The following is a description of a gene set: Reactome Pathway: Defective SLCO1B1 causes hyperbilirubinemia, Rotor type (HBLRR) The solute carrier organic anion transporter family member 1B1 (SLCO1B1) is expressed on the basolateral surfaces of hepatocytes and mediates the uptake of bilirubin (BIL), a breakdown product of heme degradation, to the liver where it is conjugated and excreted from the body. Defects in SLCO1B1 can cause hyperbilirubinemia, Rotor type (HBLRR; MIM:237450), an autosomal recessive form of primary conjugated hyperbilirubinemia. Mild jaundice, not associated with hemolysis, develops shortly after birth or in childhood (van de Steeg et al. 2012, Sticova & Jirsa 2013, Keppler 2014). studied in species Homo sapiens part of: SLC transporter disorders, and this is the list of marker genes: SLCO1B1